Given this list of marker genes NDUFV1, NDUFS8, NDUFA1, ELOVL4, NDUFV2, NDUFAF4, NDUFS7, PRPH2, NDUFB9, NDUFA11 (NADH:ubiquinone oxidoreductase subunit A11), SLC35A2, NDUFS1, NDUFB10, NDUFS2, NDUFAF1, MT-ND3, TMEM126B, NDUFB11, NDUFS3, NDUFA6, NDUFB3, TIMMDC1, PSAT1, CNGB3, MT-ND2, NDUFAF2, FOXRED1, NKX6-2, ABCA4, NDUFAF3, NDUFAF5 (NADH:ubiquinone oxidoreductase complex assembly factor 5), NDUFS4, MT-ND1, PROM1, NUBPL, NDUFS6, NDUFAF8, SLC2A1, here is a description of the gene set: Sudden-onset episode of abnormal, involuntary eye movements. Human Gene Set: HP_PAROXYSMAL_INVOLUNTARY_EYE_MOVEMENTS Paroxysmal involuntary eye movements species: Homo sapiens